The following is a description of a gene set: Human Gene Set: GOBP_NEGATIVE_REGULATION_OF_TRANSCRIPTION_REGULATORY_REGION_DNA_BINDING studied in species Homo sapiens Any process that stops, prevents or reduces the frequency, rate or extent of transcription regulatory region DNA binding., and this is the list of marker genes: HEY2, GATA1, PSEN1, ZNF593, SOX11 (SRY-box transcription factor 11)